Given this list of marker genes TLR6, MARK4, BRCC3, ZDHHC5, ZDHHC1, KCNK6, PRKD1, TLR4, MYD88, DHX33, NEK7, PPP2CA, MAPK8, LATS1, DDX3X, GBP5, MAVS, P2RX7, LATS2, USP50, STMP1, ATAT1, PLCG2, BTK, MARCHF5, CD36, GBP2, PTPN22, here is a description of the gene set: Human Gene Set: GOBP_POSITIVE_REGULATION_OF_INFLAMMASOME_MEDIATED_SIGNALING_PATHWAY species: Homo sapiens Any process that activates or increases the frequency, rate or extent of an inflammasome-mediated signaling pathway.